The following is a description of a gene set: Human Gene Set: MODULE_35 studied in species Homo sapiens Genes in the cancer module 35., and this is the list of marker genes: LIG1, EPRS1, VARS1, IARS1, YARS1, LARS2, CARS1, NARS1 (asparaginyl-tRNA synthetase 1), HARS1, QARS1, AARS1, GARS1, HARS2, KARS1, KHSRP, SARS1